Given this list of marker genes GCNA, FAM111A (NCBI Gene Id 63901), TEX264, BRIP1, HMCES, VCP, SPRTN, TRAIP, VCPIP1, here is a description of the gene set: The removal of covalent cross-link between DNA and a protein. studied in species Homo sapiens Human Gene Set: GOBP_PROTEIN_DNA_COVALENT_CROSS_LINKING_REPAIR